Given this list of marker genes IRS2, PIK3R1, FLT3, AGAP2, LYN, SH3GLB1, PRKD1, here is a description of the gene set: studied in species Homo sapiens Binds to and increases the activity of a phosphatidylinositol 3-kinase (PI3K). Human Gene Set: GOMF_PHOSPHATIDYLINOSITOL_3_KINASE_ACTIVATOR_ACTIVITY